Given this list of marker genes Gm18820 (predicted gene, 18820), Or8b9, Gm31013, 5033425B01Rik, Gm6796 (NCBI Gene Id 639166), Jam3, Dpy19l1, Esam, Gm22380, Hepacam, Siae, Or8b35, Gm18891, Tbx20, Or8b4, Gm47680, Panx3, Vsig2, Gm3867, Gm31408, Barx2, Foxred1, Or8b8, Gm27219, Gm5614 (NCBI Gene Id 673609), Gm39312, Pus3, Gm39317, Gm24764, Stt3a, Gm27235, Zbtb44, Eepd1, Gm33838, Opcml, Gm15520, Gm47496, Gm1110, Kcnj1, 2610105M22Rik, Gm27162, Glb1l2, Pate4, Gm27166, Gm3434, Tmem45b (NCBI Gene Id 260382), Ntm, Spa17, Fez1, Or8a1, Or8c1-ps1, Pate5, Cypt4, Or8b12b, Gm26787, Kirrel3, Gm8343, Gm8162, Gm48716, Gm10177, Igsf9b, Gm18585, Gm7244, Gm29824, Gm5120, Ets1, Ddx25, Herpud2, Msantd2, Gm25439, Gm5916, Pate2, Tirap, Spata19, Gm18377, Robo4, Dpy19l2, Gm17508, Gm6762, Pate10, Gm47481, Vps26b, Or8b36, Pate14, Gm3896, Pate9, Ccdc15, Gm3428, Robo3, Or8a1b, Gm10701, Gm8171, Gm25861, Ncapd3, Arhgap32, St3gal4, Tbrg1, Gm19640, Ei24, Tpi-rs4 (NCBI Gene Id 384926), Gm25630, Rpusd4, Gm22060, Gm8049, Gm16071, Pate12, Tmem218, Pate11, Glb1l3, Hyls1, Gm30313, Adamts15, Amd-ps6, Adamts8, 4930434F21Rik, Or8c12-ps1, B3gat1, Vsig10l2, Slc37a2, Gm32171, Gm29724, Or8b101, Nrgn (neurogranin), Thyn1, Pate13, Tmed2b, Gm18329, Snx19, Or8b38, Rps2-ps12, Or8b12, Gm3331, Olfr880-ps1, Gm34885, Acad8, Dcps, Kirrel3os, Tpt1-ps5, Cdon, Gm29642, Gm8031, Gm8106, St14, Or8b40, Prdm10, Pate6, Gm10105, Pate8 (NCBI Gene Id 100312948), Aplp2, Gm31497, Fam118b, Gm47465, E130101E03Rik, Gm3756, 4933422A05Rik, 1700027I24Rik, Pate3, Gm18226, Or8b37, Gm39318, Acrv1, Srpra, Gm25346, Gm15521, Pate7, Or8p1-ps1, Kcnj5, Pknox2, Chek1, Fli1, Gm19113, Gm30933, Pate1, Or8b39, Or8b12c, Nfrkb, 7630403G23Rik, Gm48393, 4930581F22Rik, Septin7, here is a description of the gene set: Mouse Gene Set: chr9A4 species: Mus musculus